Given this list of marker genes HCN4, CNGB3, CNGB1, AQP1, HCN1 (hyperpolarization activated cyclic nucleotide gated potassium channel 1), KCNA10, CNGA1, CNGA2, HCN2, CNGA4, CNGA3, here is a description of the gene set: studied in species Homo sapiens Enables the transmembrane transfer of an ion by a channel that opens when a cyclic nucleotide has been bound by the channel complex or one of its constituent parts. Human Gene Set: GOMF_CYCLIC_NUCLEOTIDE_ACTIVATED_MONOATOMIC_ION_CHANNEL_ACTIVITY